The following is a description of a gene set: studied in species Homo sapiens Synostosis of carpals/tarsals The carpus consists of the scaphoid, lunate, triquetal, pisiform, captitate, hamate, trapezoid, and trapezium bones. The tarsus consists of the talus, calcaneus, cuboid, cuneiform, and navicular bones. This term applies if there is any fusion among the bones of the carpus or tarsus. Human Gene Set: HP_SYNOSTOSIS_OF_CARPALS_TARSALS, and this is the list of marker genes: SALL4, RECQL4, FGFR2, DYNC2LI1, APC, MAP3K7, FLNB, LMBR1, NOG, COL27A1, ROR2, B3GALT6, GDF5, RBM8A, BPNT2, TPM2, OFD1, FGFR3, RNU12, BHLHA9, PAX3, HOXA13, PRKACA, HOXD13, FBLN1, GDF6, POR, CHSY1, EVC2, PRKACB (protein kinase cAMP-activated catalytic subunit beta), SMOC1, TNNI2, BMPR1B, FGFR1, ATP7A (ATPase copper transporting alpha), GLI3, NALCN, PITX1, NXN (NCBI Gene Id 64359), MKKS (MKKS centrosomal shuttling protein), MYH3, ESCO2, EVC, LRP4, MACROH2A1, GLI1, SHH, TBX4, TNNT3, FLNA